The following is a description of a gene set: The specific behavior of an organism that recur with measured regularity. species: Homo sapiens Human Gene Set: GOBP_RHYTHMIC_BEHAVIOR, and this is the list of marker genes: SIX3, NPY2R, NR1D2, ANKFN1, DRD2, CRH, CHRNB2, CIART, MTA1, NR1D1, EGR1, MTOR, NMU, NLGN1, NAGLU, GPR176, MTNR1B, GABRB3 (NCBI Gene Id 2562, gamma-aminobutyric acid type A receptor subunit beta3), USP2, EGR2, MC3R, ID2, ROGDI, BTBD9, HCRTR2, FXR1, GHRH, NPS, TP53, CSNK1E, PARP1, ADRB1 (adrenoceptor beta 1), GPR157, PER3, NCOR1, KCNA2, KCND2, ADORA2A, PTGDS, PLN, BLOC1S6, C3orf70, ADORA1, ZFHX3, PTEN, KCNQ1, GHRHR, NCOA2, GHRL, CSF2